The following is a description of a gene set: species: Mus musculus Genes up-regulated during pubertal mammary gland development between week 4 and 5. from publication McBryan J, Howlin J, Kenny PA, Shioda T, Martin F (PMID 17486082) Expression microarray analysis identified over genes regulated during puberty in the mouse mammary gland. Most prominent were genes whose expression increased in parallel with pubertal development and remained high thereafter. Members of the Wnt, transforming growth factor-beta and oestrogen-signalling pathways were significantly overrepresented. Comparison to expression data from CITED1 knockout mice identified a subset of oestrogen-responsive genes displaying altered expression in the absence of CITED1. Included in this subset are stanniocalcin2 (Stc2) and amphiregulin (Areg). Chromatin immunoprecipitation revealed that ERalpha binds to oestrogen response elements in both the Stc2 and Areg genes in the mammary gland during puberty. Additionally, CITED1 and ERalpha localize to the same epithelial cells of the pubertal mammary gland, supporting a role for interaction of these two proteins during normal development. In a human breast cancer data set, expression of Stc2, Areg and CITED1 parallel that of ERalpha. Similar to ERalpha, CITED1 expression correlates with good outcome in breast cancer, implying that potential maintenance of the ERalpha-CITED1 co-regulated signalling pathway in breast tumours can indicate good prognosis. Mouse Gene Set: MCBRYAN_PUBERTAL_BREAST_4_5WK_UP, and this is the list of marker genes: Ice1, Patj, Arhgef3, Tead2, Pias3, Csn3, Slco2a1, Fos, Htra1, Tmem158, Wfdc18, Fip1l1, Esrp1, Nfil3, Tmem40, Impdh2, Preb, Capg, Ceacam1, Tmprss2, Vwf, Ttpa, Prlr, Spon1, Nhsl1, Il33, Actg2, Pdlim2, Jpt1, Muc15, Cd24a, Col9a1, Col16a1, Stambpl1, Atp5if1, Id4, Iigp1, Thbs1, Acot1, Scin, Cldn3, Sox9, Folr1, Wnt2, Tgif1, Rpl22, Grhl2, Ikbip, Arg2, H2-Eb1, Rab7b, Trp63, Csn1s1, Rnd3, Rnf128, Csn2, Fbln7, Ripor2, Mfge8, Klf5, Csn1s2a, Upk3a, Ezr, Slpi, Irx5, Padi2, Gas1, Cemip2, Epcam, Spint1, Plat, Tasor2, Mboat1, Ly6d, Prom2, Tmed3, Cpt1a, Clca3a2, Tnfrsf12a, Dpysl3, Ripk4, Spon2, Plekhb1, Tgfb3 (transforming growth factor, beta 3), Mafb, Cap1, Adamts5, Areg, Cdcp1, Ocln, Irf6, Enah, D17H6S56E-5, Cxcl14, F3, Chi3l1, Rab25, Inmt, Wdr43, Cntn1, Npr3, Irak1, Rps10, Bspry, Mark1, Pof1b, Errfi1, Sdc1, Rpl36a (ribosomal protein L36A), Fxyd2, Cystm1, Krt14, Zbtb8a, Tgm2, Stc2, Rab17, Irx1, Trps1, Spp1, Stard10, Thbs2, Gas6, Irx3, Plet1, Ltf, Bex1, Esrp2, Tacstd2, Prom1, Trmt1, Bcl6, Aldoc, Cotl1, Sdc4, Epb41l4b, Rpl5, St14, Fbxo32, Hey1, F2r, Apod, Cxcl15, Ptn, Wwc1, Elapor1, Ptprk, Fgfr2, Gzma, Tlcd4, Zfp704, Lad1, Fign, Nfkb2, Dkk3, Fen1, Boc, Id2, Tnfaip6, Shroom3, Tnfaip2, Ddr1, Mmd2, Retreg1 (reticulophagy regulator 1), Fn1, Kcnk1, Sesn3, Perp, Gipc2, Lalba, Jun, Cd9, Mkrn1, Pdzk1ip1, Galnt3, Vcan, Becn1, Tnc, Dusp6, Slc39a6, Cldn4, Fzd6, Sfrp1, Ctse, Elf5, Wfdc2, Tuba4a, Tmem30b, Btn1a1, Timp1, Spns2, Irx2, Hdac11, Gsta3, Ano1, Plpp2, Myb, Dusp16, Hspa1b, Slc44a2, Krt8, Sox4, Arhgap21, Igfbp2, Dsp, Gdpd1, Tle3, Fhdc1, Cldn7, Pla2g7 (NCBI Gene Id 98095), Cdh1, Igfbp6, Ifi202b, Atp6v1b1, Emb (NCBI Gene Id 218679), Nxn (NCBI Gene Id 18230), Egr2, Cyb561, Gata3, Erbb3 (erb-b2 receptor tyrosine kinase 3), Col7a1, Slc2a1, Rpl37a, Vasn, Sat1, Foxa1, Palld, Tspan8, Lcn2, Isyna1, Aldh1a1, Ptx3, Cldn8, Atp1a3, Krt7 (NCBI Gene Id 28074), Plk2, Serpinb11, Txndc16, Sfxn3, Tfap2c, 2610528J11Rik, Pdlim4, Pfn2, Marcksl1, Kif22, Aqp5, Cd14, Rbp1, Cald1, Mdk, Acta2, Atp1a1, Pawr, Cracr2b, Runx1, Abcc3, Cdh11, Tpbg, Inhbb, Mansc1, Cnn3, Atp2c1, Cldn10, Krt18, Cited1, Krt19, Plac8, Cck, Faap20, Serpinb5 (NCBI Gene Id 98414, serine (or cysteine) peptidase inhibitor, clade B, member 5), Hebp2, Ehf, Bex3, Fxyd3, Cnn1, Synpo